Given this list of marker genes TSHZ2, CTSS (cathepsin S), FRMD4B, FAM210B, C1QB, RPS27, MICAL1, RPL23, LYZ, MYCN (MYCN proto-oncogene, bHLH transcription factor), SSTR2, SUFU, YBX3, SOX18, IER5, MCM6, MAP2K6, RAD51AP1, FZD2, PLEKHO2, DDR2, C1QA, C4A, RND3, CAVIN2, ZEB1, POLE, PPAN, KMT5A (NCBI Gene Id 387893), KATNIP, GLI1, HK2, LRIG3, CDK6, CCND1 (cyclin D1), HLA-DQA2, CKLF (NCBI Gene Id 51192), AKNA, MAGOHB, CDCA7, SFRP1, MCM2, CCND2, CDH20, GPNMB (glycoprotein nmb), PTCH2, LAP3, HSD11B2, EIF4EBP1, GLI2, IRS1, TBATA, B2M, SOCS2, MTHFD2, ATOH1, here is a description of the gene set: The Sonic Hedgehog (SHH) signaling pathway is indispensable for development, and functions to activate a transcriptional program modulated by the GLI transcription factors. Here, we report that loss of a regulator of the SHH pathway, Suppressor of Fused (Sufu), resulted in early embryonic lethality in the mouse similar to inactivation of another SHH regulator, Patched1 (Ptch1). In contrast to Ptch1+/- mice, Sufu+/- mice were not tumor prone. However, in conjunction with p53 loss, Sufu+/- animals developed tumors including medulloblastoma and rhabdomyosarcoma. Tumors present in Sufu+/-p53-/- animals resulted from Sufu loss of heterozygosity. Sufu+/-p53-/- medulloblastomas also expressed a signature gene expression profile typical of aberrant SHH signaling, including upregulation of N-myc, Sfrp1, Ptch2 and cyclin D1. Finally, the Smoothened inhibitor, hedgehog antagonist, did not block growth of tumors arising from Sufu inactivation. These data demonstrate that Sufu is essential for development and functions as a tumor suppressor. from publication Lee Y, Kawagoe R, Sasai K, Li Y, Russell HR, Curran T, McKinnon PJ (PMID 17452975) species: Mus musculus Genes up-regulated in medulloblastoma tumors from animals with inactivating mutations of one copy of PTCH1 or SUFU in conjunction with TP53 loss. Human Gene Set: LEE_TARGETS_OF_PTCH1_AND_SUFU_UP